Given this list of marker genes Nfib, Sox18, Terc, Tial1, Thpo, Pim1, Wnt5a, Babam1, Osr2, Septin4, Arih2, Rnf43, Rbpj, Wnt2b, Ptprc, Cebpa, Prrx1, Sart3, Tgfb1 (NCBI Gene Id 21803), Abcb1a, Fgf8, Lig4, Ncoa3, Ltbp3, Dab2, Tgfbr2, Hoxa3, Lrp6, Ythdf2, Ift80, N4bp2l2 (NCBI Gene Id 78325), Xrcc5, Ctnnb1, Men1, Cxcl1, Mecom, Irf6, Ndufs6, Scrg1, Hmx2, Abcb1b, Bmp4, Trim71, Cd109, Nfatc1, Hoxb4, Trp63, Mir145a, Axin2 (axin 2), Sox17, Dsg2, Znrf3, Foxm1, Wnt3, Mir143, Mpl, Kdf1, Nes, Bysl, Tlx1, Tert, Pbx1, Atxn1l, Fgfr2, Tgfbr1, Sirt6, Ell3 (elongation factor RNA polymerase II-like 3), Epcam, Irgm1, Mir145b, Nr2e1, Wnt1, Ercc2, Fgf2, Tbx18, Cdkn2c, Ngf, Shh, Ago3, Trp53, Yap1, Etv6 (NCBI Gene Id 14011), Fubp1, Taf4b, Ccne1, Gli2, Snai2, Dppa2, Setd1a, Cd34, Prg4, Ovol1, Shox2, Six2, Hnrnpu, L3mbtl2, Gja1, Notch1, Dgcr8, Eif2ak2, Ptch1, Sox9, Kdr, Vegfc, Fbln1, Rarg, Fermt2, Fermt1, Ovol2, Wnt11, Prrx2 (NCBI Gene Id 20204), AY074887, Sox11, Fgf4, Kitl, Kdm1a, Kat7, Prl2c3 (NCBI Gene Id 26421), Zfp36l1, Nf1, Pax3, Mir320, Fgfr1, Ace, Ctc1, Gli3, Tbx3, Ang, Sfrp2, Hmgb2, Nkap, Rarb, Mki67, Pdcd2, Brca2, Hmga2, Ttyh1, Yjefn3, Shb, Mir205, Fgf10, Tsc22d1, Hdac5, Wnt10b, Runx2, Gba1 (NCBI Gene Id 14466), Fgf9, Nf2, Mir702, Sfn, here is a description of the gene set: species: Mus musculus Mouse Gene Set: GOBP_STEM_CELL_PROLIFERATION The multiplication or reproduction of stem cells, resulting in the expansion of a stem cell population. A stem cell is a cell that retains the ability to divide and proliferate throughout life to provide progenitor cells that can differentiate into specialized cells.